Given this list of marker genes CD28, CTLA4, ERCC4, LMNA, FERMT1, ANAPC1, XPA, ERCC2, ERCC3, BLM, FAM111B, USB1, ERCC6, XPC, TNFRSF1B, ERCC5, RNU7-1, LTV1 (LTV1 ribosome biogenesis factor), RECQL4, DNA2, POLH, IARS2, MTX2, DDB2, COL7A1, here is a description of the gene set: studied in species Homo sapiens Poikiloderma Poikiloderma refers to a patch of skin with (1) reticulated hypopigmentation and hyperpigmentation, (2) wrinkling secondary to epidermal atrophy, and (3) telangiectasias. Human Gene Set: HP_POIKILODERMA